The following is a description of a gene set: species: Homo sapiens Human Gene Set: GSE41867_NAIVE_VS_DAY30_LCMV_ARMSTRONG_MEMORY_CD8_TCELL_UP During acute viral infections, naïve CD8+ T cells differentiate into effector CD8+ T cells and, after viral control, into memory CD8+ T cells. Memory CD8+ T cells are highly functional, proliferate rapidly upon reinfection and persist long-term without antigen. In contrast, during chronic infections, CD8+ T cells become “exhausted” and have poor effector function, express multiple inhibitory receptors, possess low proliferative capacity, and cannot persist without antigen. To compare the development of functional memory T cells with poorly functional exhausted T cells, we generated longitudinal transcriptional profiles for each. from publication Doering TA, Crawford A, Angelosanto JM, Paley MA, Ziegler CG, Wherry EJ (PMID 23159438) Genes up-regulated in CD8 T cells: naïve versus memory at day 30 after acute infection with LCMV-Armstrong., and this is the list of marker genes: CYP20A1, NT5C3B, TUFM, UTP23, SELENOW, MAPRE2, POGLUT2, DYNLL2, USP15, AGA, TNFSF9, PPIL1, TRAPPC1, ACACA, KPNB1, GSR, CAAP1, PACRGL, NUDC, NUP107, POLDIP2, RBM4, YIPF2, KCTD9, CDC123 (cell division cycle 123), NAA10, TUBD1, WASHC1, ZNF277, SEL1L, SEPTIN9, MOV10, EIF2B5, PIN4, IFT27, BTD, GNPDA2, MIEF2, COPB2, ATP5F1E, HPF1, FCER2, RMDN2, PPAT, GYG1, PPP4R3B, PARD6A (NCBI Gene Id 50855), RPAP3, MAMDC2, NUP50, ZDHHC16, HINT3, MRPL14, SARNP, MRRF, MRPL23, KBTBD4, AUP1, CTBS, SDF4, LAMTOR1, UMPS, RPS19BP1, REN, DRG2, ZNF518B, HYLS1, PTDSS2, FOXRED1, MRPL22, COMMD1, ZC3H15, WDR55, ERMP1, RBBP4, TEX261, CCRL2, CASP6, SMCHD1, MCRIP2, MUS81, MRPL9 (NCBI Gene Id 65005), NAT1, CEP76, GDPGP1, ORC3, SNRNP25, ARFGAP3, DPY30, PMFBP1, MCMBP, PHF5A, SEC22B, NDUFA4, LIN28A, ARL6, DCUN1D5, ZNF771, PDP2, SMIM8, MRPS11, ISG20, FANCL, BID, CDC26, TIMMDC1, GLT8D1, MTRF1L, TCEA1, HINT1, CKAP5, ZNF239, JAGN1, NDUFA12, NDUFS4, ALAD, ANAPC7, RBM43, LBR, NSMCE1, GPATCH4, RPL18, DTNBP1, HSPA13, RDH12, IFITM3, ACOT7, ARF5, PHPT1, ESD, LSM3, ZMAT3, TMPO, RBM44, NRBF2, TRIM5, PAPLN, COX19, ATP5MC1, RAB8B, FDX1, VPS36, THAP11, GABPA, CENPJ, NAA15, SREBF1, FAM78A, XPNPEP1, PRR36 (proline rich 36), ATXN1, EIF3J, S1PR4, SOD1, COX17, TAF10, ZNF574, SLC25A12, MINPP1, FLAD1, TSPYL4, INTS9, ANAPC13, ZNF141, GNE, PGM1, PHF7, NVL, CERS6, GNB4, GRPEL1, CD96, TOR2A, SAP18, ZNF217, OPTN, ELOF1 (elongation factor 1), SYS1, PGM2L1, COA8, ZBTB32, STT3A, ADH5, GKAP1, PARP11, CUEDC2, EOLA1, JAK2, CD48, DDIAS, AP1G1, NUDT19, COQ7, CRNKL1, TIMM23, NDUFA7, ZNHIT2, RAD51B, PDCD2